The following is a description of a gene set: studied in species Mus musculus Mouse Gene Set: GOBP_POSITIVE_REGULATION_OF_INTERLEUKIN_2_PRODUCTION Any process that activates or increases the frequency, rate, or extent of interleukin-2 production., and this is the list of marker genes: Prkcq, Sptbn1 (spectrin beta, non-erythrocytic 1), Abl2, Rps3, Card11, Pde4d, Pnp2, Il1a, Ccr2, Stat5a, Abl1, Cd276, Glmn, Irf4, Cd3e, Pnp, Prkd2, Defb25, Cd1d1, Map3k7, Il1b, Vtcn1, Cd28, Traf2, Traf6, Tnfsf4, Sash3, Runx1, Cd83, Ripk2, Pde4b, Anxa1, Malt1, Clec7a, Carmil2, Stat5b, Btnl2, Cd1d2, Stoml2, Plcg2, Ptprc (protein tyrosine phosphatase receptor type C)